Given this list of marker genes PIAS3, RXRA, GATA1, ID1, SUPT4H1, DHX9, NAP1L2 (NCBI Gene Id 4674), E2F1, EIF4A2, ANKRD49, ZBTB17, PBX2, FOXH1, HMGN2, PER3, NFIX, MBD4, POLR2J, IRF8, CDKN2D, HMGB2, SMAD6, FEN1, AURKB, SRSF2, KLF1, TFDP1, EXO1, PIAS2, RAB2A, FOSL2, ATF1, SP3, PLA2G6, CENPA, TCF12, HNRNPDL, BMI1, SMARCB1, HMGB3, RAB7A, CUX2, CENPB, here is a description of the gene set: from publication Riz I, Akimov SS, Eaker SS, Baxter KK, Lee HJ, Mariño-Ramírez L, Landsman D, Hawley TS, Hawley RG (PMID 17213805) Aberrant expression of the human homeobox-containing proto-oncogene TLX1/HOX11 inhibits hematopoietic differentiation programs in a number of murine model systems. Here, we report the establishment of a murine erythroid progenitor cell line, iEBHX1S-4, developmentally arrested by regulatable TLX1 expression. Extinction of TLX1 expression released the iEBHX1S-4 differentiation block, allowing erythropoietin-dependent acquisition of erythroid markers and hemoglobin synthesis. Coordinated activation of erythroid transcriptional networks integrated by the acetyltransferase co-activator CREB-binding protein (CBP) was suggested by bioinformatic analysis of the upstream regulatory regions of several conditionally induced iEBHX1S-4 gene sets. In accord with this notion, CBP-associated acetylation of GATA-1, an essential regulator of erythroid differentiation, increased concomitantly with TLX1 downregulation. Coimmunoprecipitation experiments and glutathione-S-transferase pull-down assays revealed that TLX1 directly binds to CBP, and confocal laser microscopy demonstrated that the two proteins partially colocalize at intranuclear sites in iEBHX1S-4 cells. Notably, the distribution of CBP in conditionally blocked iEBHX1S-4 cells partially overlapped with chromatin marked by a repressive histone methylation pattern, and downregulation of TLX1 coincided with exit of CBP from these heterochromatic regions. Thus, we propose that TLX1-mediated differentiation arrest may be achieved in part through a mechanism that involves redirection of CBP and/or its sequestration in repressive chromatin domains. studied in species Mus musculus Selected gradually up-regulated genes whose expression profile follows that of CCNE1 in the TLX1 Tet On iEBHX15-4 cells (pro-erythroblasts). Human Gene Set: RIZ_ERYTHROID_DIFFERENTIATION_CCNE1